Given this list of marker genes Entpd5, Upp2, Nt5c3, Entpd7, Cda (NCBI Gene Id 72269), Dpys, Entpd4b, Nt5c, Entpd4, Dpyd, Upb1, Upp1, here is a description of the gene set: Mouse Gene Set: GOBP_PYRIMIDINE_RIBONUCLEOTIDE_CATABOLIC_PROCESS The chemical reactions and pathways resulting in the breakdown of a pyrimidine ribonucleotide, a compound consisting of nucleoside (a pyrimidine base linked to a ribose sugar) esterified with a phosphate group at either the 3' or 5'-hydroxyl group of the sugar. species: Mus musculus